Given this list of marker genes CEP76, CKAP5, VPS41, ZSCAN12, RTEL1, ENPP3, BNIP1, FAM185BP, MDH1 (malate dehydrogenase 1, NCBI Gene Id 4190), LTV1, FLAD1, GTF2IRD1P1, PSMD3, ANAPC2, MORC2, DNTTIP2, YIPF2, SLC44A1, RNA5SP473, CTR9, TTC31, SKIC3, SSNA1, MTFR2, TARDBP, EMC4, NFKBIL1, CRYZ, RPS3A, MED24, GDAP1, TIMM23, SFTA2, FAM98B, CCAR2, TVP23B, SNU13, OPLAH, ZNF581, KLK2, ZNF623, RPS28 (ribosomal protein S28), PRPSAP1, ZNF629, CHML, SENP7, RNF115, NDUFS7, PSTK, RER1, DHX33, ASB3 (NCBI Gene Id 51130), CBFB, CDC123 (cell division cycle 123), SMPD4 (sphingomyelin phosphodiesterase 4), TMEM245, COX6C, NAGPA, AOC1, CEP44, STRIP1, MRPL3, DNAAF11, U2SURP, BLOC1S5-TXNDC5, ERLIN2, BBS5, RNF185, GUCD1, CFAP68, LUC7L, NUP107-DT, YAE1-DT, SMARCAD1, FBXO8, USP37, RPUSD2, URB1, CXXC1, NOL8, RPS3, C6orf52, MCMBP, PINX1, CDKL3, LINC01547, FBXO45, ENDOV, NDC1, DNAAF10, GPATCH4, GPR89A, NKAPP1, NDUFV3, VPS13B-DT, NUP85, RTTN, OPN3, USP30, SSU72-AS1, PRR3, SYT12, TRIAP1, TMED1, TIGD4, NAF1, SLC35A1, FEN1, LAMTOR5, TBP, CSTF2T, COQ3, BRD7, TMEM41A, POLR1H, METTL6, SPHK2, ANGPTL4, TXN2, MIR4766, UBQLN1, FIZ1, WDR31, C2orf49-DT, VPS50, ST7 (NCBI Gene Id 93655), ADO, SNRNP27, CCNC, ZNF805, TSN, ARV1, BRWD3, EIF2S1, PITHD1, RTF2, LARS2, WIPF2, SRGAP3, NKAP, INTS1, TFIP11, IFRD2 (interferon related developmental regulator 2), ADSS2, VPS72, MACC1, NR2C1, RAB2B, GBA1LP, EIF2B5-DT (NCBI Gene Id 105374249), SERP1, WASHC2C, KRT18P33, SMG5, NUCKS1, NUDT5, HINT3, SUGP1, PLAA, MRPL54, NHP2, SLC7A6OS, KRR1, PSMG3-AS1, DDX18, TMED10, CENPS-CORT, ZBED5, SPNS1, CCT7, CHD8, USP40, MCF2L2, VARS2, ISY1, NUP205, ZNF133, SELENOOLP, SP2, SEPTIN7P14, ADNP, EEF1A1P23, LZTFL1, PCID2, C19orf81, KCNH2 (potassium voltage-gated channel subfamily H member 2), RBSN, EIF3H, EMC3, BUD13, YAE1, RAB18 (RAB18, member RAS oncogene family), WTAP, YBX1, COMMD3, ABCF2, MIR762HG, LINC03016, COMMD9, MTPAP, DOHH (NCBI Gene Id 83475), ZSCAN21, TIMM29, SCG3, EXOC4, ORMDL3, CHUK, LARP4 (NCBI Gene Id 113251), ZNF165, SLC38A6, ATP8A1-DT, INO80C, POLR1HASP, HSPB1P2, MORC1, ADSS1, NDUFAF5, PIH1D2, CCT4, PCSK6, SHARPIN, C8orf33, LINC01347, MRPL27, ZNF3, COMMD1, SMG8, TMEM230, ERI3, ADPRS, RFC3, TRIP4, EXOSC8, NUP133-DT, RPS7, GFI1B, PIGL, RPL29, CCNI, PEF1-AS1, FARS2, VPS51, ZDHHC6, MED23, GTPBP10, CWC25, PTPN11, MTBP (NCBI Gene Id 27085), ATP5PD, MRPS34, PSMD8, BAD, CNOT10, FAM21EP, GPS2, LRRC37A5P, IDH3B-DT, ZNF688, YJU2, CDKN2C, S100PBP, MIR5091, UFSP1, TSPYL6, DDX55, ISY1-RAB43, MAPKAPK5-AS1, ZFHX2, ZNHIT3, PPP4R1L, HEXA-AS1, PARG, CWC22, PRR14, ROMO1, SLC38A9, EIF3G, PRPF18, ZNF417, NME1, EIF5A, RTEL1-TNFRSF6B, SIN3B, SMPD4BP, CMSS1 (cms1 ribosomal small subunit homolog), PINX1-DT, MRPS31P5, SECISBP2, PPP2R3B, TOR1A, IFRD1, EXOC1, BBS1, SLC4A1AP, ENSG00000253986, ZBTB40, PSMA1, ZNF26, RNPC3, ALG10, RABGGTA, ZNF426, ADSL, POLR2J4, EEFSEC, CDKN2AIPNL (CDKN2A interacting protein N-terminal like), PPP4R3B-DT (PPP4R3B divergent transcript), SUB1, POLR3C, ACAD11, PPP4R3B, TMEM79, NRBF2, PCM1, HNRNPH2, MTLN, NKAPD1, NXT2, NDUFA12, SLX9, RRAGA, ARMC8, KLHL20, DNAJC1, TAF2, NBAS, AP4M1, FMC1, AFG2B, MEN1, REX1BD, RCAN1, NSUN6, DIABLO, DHODH, UQCC4, NFE2L1, GOLGB1, POLR2M (NCBI Gene Id 81488), AGA, LRRC59, LINC02842, SART1, ENSG00000263011 (NCBI Gene Id 124903629, novel transcript, sense overlapping ZNF205), GSTCD, ENSG00000232995, COPS8-DT, EMC2, SNORA50C, PPIP5K2, MKRN2, CERNA3 (competing endogenous lncRNA 3 for miR-645), GLB1L, NGDN, UBB, NDUFB7, COASY, SEC22B, MIX23, GPBP1, GTF2H4, INTS2, ZFPM2-AS1, MTF2, EIF2B1, SCP2, UBAP2L, SOCS1, MED28-DT, STOML2, RFC4, LIAS, CFAP52, CYB5RL, MKRN3, TMT1B, MCM8, TAF13, CDK12, TBC1D13, PANK4, ARFRP1, C1QL4, GLA, NELFA, PPP1R12B, AK6, HCG21, KLHDC4, RPLP0, SRP54-AS1 (NCBI Gene Id 102723366), ERBB2, NDUFV1, DDX1, MRPS23, RPF2, MCM7, ZDHHC7, STAM2, STMN3, SMG7-AS1, TEFM, GUSBP1, FAM228B, GARS1-DT, MRPL9, METTL2B, CRY1, RBBP4, CCDC86, IMPACT, TIGD6, ECSIT, RAB30-DT, PSMC3, PEX16, NORAD, TMEM14B, TUT1, PUM3, KLHDC9, KBTBD6-DT, CLUAP1, WDR37, KIF15, MRPL20, UBE2I, HERPUD2, MRPL53, BRMS1, ZNF408, FBXL12, VPS4B, TMEM205, CALM2, LSM10, ZSWIM8, MAPKAPK5, ARSK, MIS18A, IFT74, RPS25, MRPS31, RPTOR, ANKRD17-DT, DTL, PWP1, ENSG00000260830, ACO2, TMCO1-AS1, PEX26, RPA3, IKBKB-DT, BPNT1, SF3A3, CIAO3, MRPL40, MPLKIP (NCBI Gene Id 136647), UBC, ATF6-DT, TACO1 (NCBI Gene Id 51204), ZNF490, DPM3, EXOSC3, TMEM242, FAHD1, MIR4727 (microRNA 4727), HPS4, TBCCD1, TM9SF2, MRPL47, CHMP1B, EME1, DHX40, PEX14, TTC4 (tetratricopeptide repeat domain 4), CCZ1, ZNF221, CCDC146, BRPF1, GFM2, CDK7, TTC13, ZCCHC9, NME7, CDK5RAP1, LINC00680, NABP2, PCSK6-AS1, GINS3, PIGG, EIF3E, ITFG2-AS1, FASTKD2, BCL2L2, WDR53, FAM220A, LEMD2, GTF3C3, NSMCE2, PDE12, ENSG00000268129, MLEC, UFC1 (ubiquitin-fold modifier conjugating enzyme 1), TOX4, ZSCAN25, NUDT19P5, UBE4A, ZNF846, ANKRD40, ELP3, ANKRD17 (NCBI Gene Id 84177), PRADC1, NMRAL1 (NCBI Gene Id 57407), TAB3, EPCIP-AS1, SP8, RRP15, ZSCAN9, GM2A, HDAC4-AS1, METTL9, JRK, PPIG, GEMIN7, ZNF131, SEC11A, TRMT10C, TRPC4AP, FANCD2 (FA complementation group D2), LL22NC03-63E9.3, PFDN4, BRF2, BMS1, ATAD3A, NRAS, HELQ, BOD1L1, CHFR-DT, TXNL1, C1orf35, MYL12-AS1, FEM1A, AQR, PRKAB2, KAT5, CGGBP1, UMAD1, LDAH, ALS2, ZC3H18, IQCK, SLC35A5, SZT2, SCO1, PLEKHM3, BBX, FBXL18 (NCBI Gene Id 80028), CACYBP, TIMM10, NUP155, TENT2, WDR83OS (WD repeat domain 83 opposite strand), ESF1, RNF14P2, SUMF1, GMFB, HERPUD2-AS1, UBXN6, APTX, TRDMT1, TBCK (TBC1 domain containing kinase), ATP6V1H, USP31, GALNT16-AS1, GARS1, THAP8, DLAT, MMACHC, ADAT2, GTF2IP12, MRPL45P1, MINCR, PRPF31, AP4E1, MTO1, TJAP1, LYRM4, CCDC159, ADGRG7, ZNF524, PARL, SSU72, ENSG00000189229, FERRY3, EIF3F, MRPL1, SMG7, KBTBD6, DNAJC25-GNG10, SNHG17, PRIM2, FBXO7, PMF1-BGLAP, RPL18, POLR3A, CFAP57, ZNF205, OPA1, THUMPD1, CSTF2, FAM114A2, KCTD9, RIF1, DCP1A, UBP1, AKAP3, STK16, SRRD, WDR25, TOMM22-DT, VPS54, CYREN, NBPF25P, DNAJC16, FAF1, TUBGCP6, METTL15, RRM1, CSTPP1, COQ4, NAPG, TBL3, C12orf76, ACBD3, GTF2B, THAP1, SEPSECS, ZBTB8OS, RBM28, SEPSECS-AS1, SMC3, MDGA1, ZNF397, CCDC142, GTF2H3, RANBP10, B3GALT9, WDR4, GALC, C17orf75 (chromosome 17 open reading frame 75), VMAC, METTL17, TMEM208, ECHDC1, NCOA4, EDC3, ACOX3, PRAME, SESN1, NDUFB6, PATL1, CIAPIN1, POGZ (pogo transposable element derived with ZNF domain), SLC35A3, SLIRP, HARS2, POLR3B (RNA polymerase III subunit B), MAF1, SDAD1, AIMP1, AP2B1, ZNF514, ATR, ZNF223, FAM83A-AS2, PSMG3, ZKSCAN2, FIG4, PET117, PCYOX1L, CTNNB1, VCPKMT, HTRA2, URB1-AS1, MRPS15, SCAND1, WDR62, VWA8-AS1, IDH3B, NDUFA9, LAPTM4A-DT, TARS2, SNRNP35, DFFA, POLR2K, BANCR, SUPT7L, MDH1B, PGS1, PRMT7, MYO3B-AS1, ZNF396, GPATCH3, LMAN2, HYCC2, TBPL1, CLASRP, PRSS30P, DYNC2I2, PAXBP1, SLC24A1, MRPS33, CGB2, CASP9 (NCBI Gene Id 842), SNRPB, TRMT61B, TELO2, SLC39A9, ZNF461, RAD51B, ZNF785, GFM1, SPAST, MGRN1, GNG4, ST3GAL2, KIAA1143, RNMT, PSMB3, DPCD, UMPS, ISLR2, LAMP1, RALA, RAG1, MIR4519, APBA3, CENPW, TAF11, QRSL1, ANKFY1, LINC00824, PEMT, HNRNPA0, MARCHF8, SEC11C, NOC3L, TMEM167B, GIRGL, MTRF1, AP3S2 (NCBI Gene Id 8885), GUF1, NDUFB3, PARGP1, TMED9, LAPTM4A, POLR3F, RRP1B, CCN1, GPR107, TRUB2, SDHB, CALM3, SNHG25, LYST (NCBI Gene Id 1130), MAN2C1, POC1B-GALNT4, JPX, PSMB7, CHTF8, EMG1, ZNF501, BLOC1S1, MTERF1, DEDD2, UBE3B, DGCR8, HPS5, MPDU1-AS1, PTPN21, BNIP2, CWF19L1, BANP, DDX51, ZNF561-AS1, CCDC59, ZNF484, ALG1, UBE2Q1, ACAD9, ZNF791, ZNF830, CDK11B, YKT6, RPL9, SNRPF-DT, EXOC2, SCAP, ATXN2, ARHGAP1, FAM162A, MTIF2, NUTM1, NFX1, SETDB1, IQCC, LZIC, FAM135A, TSKU-AS1, CCDC124, PUS10, TMEM184C-DT, THEM4, REXO4, C2CD2L, CRBN, SNRPD3, HAGH (hydroxyacylglutathione hydrolase), FARSA, VPS26B, PHAX, ACP2, RAD17, MTERF4, SLC52A2, NDC80, EIF2D, LONP2, OAZ3, TMA16, RBM45, PFDN6, CFAP20, ALG3, SNRPC, NUP54, AHCY, CTSA, QTRT2, ZKSCAN3, DPAGT1, ZNF546, ANAPC15, TSEN15, SMARCAD1-DT, HDAC4, TMX2, ZNF391, MAPRE2, LTA4H, DHRSX, MRPL48, KDM8, MEF2A, DUS2, MCEE, ARHGEF1 (Rho guanine nucleotide exchange factor 1), TMEM248, BECN1, DNAJC7, PLD3, TNPO2, UQCC1, WDR83, ZNF197, RPSAP31 (NCBI Gene Id 391598), RPL26, NDUFB5, TFCP2, TRAPPC4, TRAF6, POC1B, ZNF268, PRKCSH, TULP2, RAD51AP1, ATF6, HOOK2, GEMIN6, ERH, C15orf40, MCTS1, ZNF426-DT, SIKE1, SLC36A1, CALCOCO1, NUP133, STAM, PPP5D1P, HEXA, SNAPC5, FLT3LG, LINC02882, SMIM12, MRPS35, ZNF394, TRMT5, TFAP2A, ARRDC1-AS1, HMGB1, CLK3, KIF9, COX7A2L (NCBI Gene Id 9167), TSNAXIP1, TMEM131, TOMM40L, WDSUB1, CHUK-DT, AAMP, TMEM9B-AS1, TRMT10A (NCBI Gene Id 93587), BMS1P4-AGAP5, ZNF317, CCNL2, PXN-AS1, FAM200A, USPL1, GUSBP11, TMEM128, MRPL30, ENSG00000293341, VPS26A, MRPS35-DT, POM121, RGS5, ABCA3, FCF1, SEC24C, HARS1, CCDC97, GORASP2, ZGPAT, FAM187A, QTRT1, TIMMDC1, TRMT44, NEK1, UVRAG, DNLZ (NCBI Gene Id 731607), ETAA1, UQCC6, RRAGC-DT, WDR24, GABARAP, ATAD2, FBXO15, SRRM5, LINC01128, RNA5SP21, GUSB, TTC1, COX19, GLUD1P3, IRGQ, ARL1, FDX2, MTMR4, MRPL55, GATC, FRMD1, GTF2IP20, SAXO1, FNBP1P1, CPNE2, EIF1AD, TOR1B, KCTD16, RNF216, SMIM30, C1orf43, MRPS31P4, ZMAT2, LRP6, WARS1, IFTAP (NCBI Gene Id 119710), NOC4L, KLHL18, AREL1, NOP10, BCL2L2-PABPN1, SNAP47, NOL7, HADHB, FAM117A, BUD13-DT, MANBAL, EIF4E2, ATAD3B, ZNF689, CCZ1P1, WASHC5, CYB561D1, ZDHHC16, SEC13, RRP36, CFAP410, ZNF502, NAT10, MTOR, PHF5A (NCBI Gene Id 84844), GIN1, WDR26, TOMM5, NCBP2, ARAP1, HIRA, TMEM101, ATL2 (NCBI Gene Id 64225), ZCCHC24, FAM50B, INTS12, ST7-OT4, TEX14, NSUN2, TBCD, HMOX2 (heme oxygenase 2), RPS20, FRA10AC1, MAP2K1, IPO4, RUVBL1, TFPT, PSMG2, MAIP1, PDE6D, CIDECP1, RLF, PDSS1, COMMD5, ZNF263, TMEM199, VAC14, CCT6B, YME1L1, DBR1, ATF7, FADS2, ABCB7, MRPS18C, SNHG33, EAF1, SNHG11, EBNA1BP2, PIGT, CDCA7, LSG1, BRIX1, TSR2, SENP1, ELF1, SRSF11 (NCBI Gene Id 9295), PALB2, PPT1, STX18-AS1, SAMM50, PNO1, ENSG00000272195, PSME3, POLR1F, LRRFIP2, ZNF16, MPHOSPH10, TOMM22, SKIC8, COX16, ERI1, TBCEL, RPIA (ribose 5-phosphate isomerase A), MIR5188, RPL4, TDG, EIF4E, WDR77, PRKCI, NECAP2, UBQLN1-AS1, CKMT2-AS1, NR1H3, CCDC163, IPO11, GNL1, CARD8-AS1, COMMD4, MZT2B, KCTD10, ATG4C, HDAC6, AURKA, POLR2C, MZT2A, INTS5 (integrator complex subunit 5), MIPEP, STEEP1, ALG10B, RNGTT, MYL12B, LINC00667, RNF187, TADA1, IFT56, KDM5C, ODAD3, JAGN1, SEC23IP, KATNB1, SAP30BP, NEK2, KBTBD4, SMIM13, THG1L, TMEM242-DT, NUDCD3, ZNF292, DBNL, AAR2, ZNF596, HEMK1, SNORD104, RANBP6, ZNF497-AS1, C2orf49, LAS1L, MRPL16, ATXN2L, STRADB, ZNF200, NEURL2, LAMTOR5-AS1, CDKAL1, MCRS1, ABCA11P, TSFM, SCYL3, SUDS3, KCTD5 (NCBI Gene Id 91152), CTDP1-DT, DNAJB12, RPL36, MFF-DT, COA1, ERLEC1, SMAP2, DNAJC30, TMEM258, EXD2, TMEM18, SLC27A5, ZNF614, PGAP3, HADHA, DYNC2H1, FAAP24, SNORD54, PRXL2B, TFIP11-DT, TYW3, AARS2, MRPL37, TSC1, GATB, ALKBH3 (NCBI Gene Id 221120), PSMB1 (proteasome 20S subunit beta 1), NDUFC2-KCTD14, BMS1P4, METTL25, PCLAF, CEP63, SNRPD1, NME1-NME2, CLPTM1, CNOT9, RIMOC1, SNRPE, LINC00115, ZNF576, LINC01098, TSKU, MCAT, ANAPC10, RRAGC, NMNAT1, WDR36, GTF2H1, SELENOH, TPI1P2, TIMM23B (translocase of inner mitochondrial membrane 23 homolog B), TIGD1, KCTD2, EFCAB7, ZNF212, GAN, ADAP2, FDXACB1, MRPL44, PCCB, MAP3K7, PHB2 (NCBI Gene Id 11331), CENPS (centromere protein S), LRRC40 (leucine rich repeat containing 40), HUS1, FBXL9P, ACCS, UTP4, MAGOH, KAT7, ZNF562, EFTUD2, CCDC174, AGGF1 (NCBI Gene Id 55109), HSF2BP, TMEM184C, LTO1, SF3B6 (splicing factor 3b subunit 6), LINC01287, FAM9B, NDUFS3, DEPTOR, MAU2, INTS14, TAF9, CARD8, ABHD17B, SNHG20, IREB2, MRPL22, C6orf89, NUFIP1, MRPL42, DRG2, POLR2J, EMC3-AS1, RABAC1, ALG5, EME2, SUPT16H, PPIL4, SLMAP, STX16-NPEPL1, RANBP2, CENPP, FBXO28, DNAJC18, RNU7-27P, MFF, WASHC2A, UBA5 (NCBI Gene Id 79876), PPP1R12C, SUGCT, ITGA7, VPS25 (vacuolar protein sorting 25 homolog), C12orf43, VWA8 (von Willebrand factor A domain containing 8, NCBI Gene Id 23078), ATP2B4, SLF1, BUD23, RTN4IP1, CLCN3, CLTC, SREK1, ERCC5, KAT14, POLDIP2, MTTP, FAM149B1, WSB1, AUP1, NOL12, STX8, THTPA, EOGT-DT, TMEM109, RPL37, ZNF561, CTBS (NCBI Gene Id 7811), MBD3L1, STX16, TRMT6, CHMP4A, WDR13, RPL23AP53, STARD10, RBBP5, GATM, RPS14, BORCS7-ASMT, KLHL12, CAMK2D, ZSCAN16-AS1, GLOD4, TM2D3 (NCBI Gene Id 80213), ATP6V1D, VPS13B, CCDC22, TRUB1, TTC32-DT, TOP3B, MICOS13, GRPEL2-AS1, CALCRL-AS1, DHX36, ZNRD2, ARL8B, GTPBP3, ATP13A4, CTDP1, PMPCB, SMIM20, INO80B, DPY19L4, AFG1L, ALKBH1, LCORL, NSA2, APOOL, VTI1A, CNBD2, HMGXB3, RECQL5, ZNF331, LINC00630, ZNF558, SEC14L1, MED15, RPS26, AP3M2, DNAJC25, ARHGEF7, MFAP3, ABCB8, CCDC103, INTS7, ECD, ATG13, TOR1AIP1, ENSG00000272008, RNF213-AS1, NUFIP2, FAM210A, UBL5, CSTF1, TAF3, MED18 (mediator complex subunit 18), CDCA2, NUF2, ABCF1, BOD1, GTF3C5, RAB30, PEF1, DPH1, ATF7IP2, SRD5A1, MITD1, SFSWAP, SEPTIN7P13, SPTLC1, MRPL13, CACTIN, LRP4-AS1, AP1G1, METTL4, STAT6, AOPEP, JMJD4, MED8, ZNF526, ZBTB17, FRS2, DDX60L, WDR70, ZBTB6, SRP54, TBC1D2, ARK2N, DHDDS, MALSU1 (NCBI Gene Id 115416), ST7-AS1, MIGA1, MRPL33, CFAP69, CNOT2, DYNC2LI1, PES1, FOXJ3, SNORD15A, ARPP19, CLPX, ABCA17P, C19orf38, ZNF2, GPR137, UBXN2B, AK9, ITGB3BP, CHCHD1, ZNRD2-DT, RAD1, CUL4A, RETSAT, MPZL3, EHMT1, LINC01666 (long intergenic non-protein coding RNA 1666), INO80B-WBP1, NDUFAF1, PRANCR, POLR2J3, TMEM167B-DT, KATNAL1 (katanin catalytic subunit A1 like 1), HSD11B1L, SLC35B1, RBL1, TMCO1, ZC3H6, EIF2A, KIAA0825, MRM3, MED27, UTP20, ZBED5-AS1, C1orf74, ZSCAN31, ATP6V1G2-DDX39B, ZKSCAN4, TPRKB (TP53RK binding protein), ATG3, FBXW9, MTX2, KNOP1, COIL, PSCA, LAMTOR3, RBM42 (NCBI Gene Id 79171), PFKM, BPGM, NDUFV1-DT, HEATR1, PNKD, C3orf85, PPP1R37, NDUFA7, TRAK2, SPPL3, ZC3HC1, MRPL20-AS1, COPS7B, ADAR, PEX13, MKLN1-AS, RAB3D, DDX31, SMTN, ZNF335, DNM1P35, BMS1P1, TNPO3, HARBI1, BORCS7, GRK4, TMEM237, WWP2, FAM21FP, FRG1, RAD54L, SNIP1 (Smad nuclear interacting protein 1), MIR3928, ABT1, POLL, EXOSC1, PDCD7, IPPK, KMT2D, ZNF580, MRPL39, EOGT, ESS2, TAF1C, CREBL2, PSMF1, TTC32, DCTN5, FBXL6, C1D, ZNF721, ZNF213-AS1, CNIH3, SAR1B, POLD3, NDUFC2, GGA1, TMEM203, DNAJB11, RIN3, C3orf38, PRMT3, RMDN3, ATP8A1, ZNF23, ALG14, CCZ1B, NOP14, PPCDC, NUP107, CHFR, ANXA2, NCBP2AS2, PPP6C, COX7B, ZNF507, XYLB, TMEM39A, GPALPP1, DZANK1, EIF2B5, FRG1GP, COX7A2, SMARCD2, CLN3, TIMM21, ZDHHC5 (NCBI Gene Id 25921), CALU, BANF1, GBA1, MTMR9, NRDE2, ATF7-NPFF, PRPF40B, CRYBG2, WDPCP, FBXW2, LINC00523, ATP5PB, TIPIN, C7orf50, NVL, RPUSD4, RNU6-271P, NDUFA11, ENSG00000221040, SPATA2, DMAP1, MNAT1 (MNAT1 component of CDK activating kinase), CNEP1R1 (NCBI Gene Id 255919), MFN2, TIMMDC1-DT, ATP5MC3, USE1, YIPF5, LUC7L2, FAM118B (family with sequence similarity 118 member B), RPF1, ASB6, ZNF644, RPL6, NAA20, RAD51C, STX18, RNPC3-DT, RPL32P3, MED28, ZWILCH, LINC01732, MAGOH-DT, RRN3, ADPGK, ZER1, COMMD2, GIHCG, SLC9A1, MARK4, THUMPD3, ZNF770, MBTPS2, LINC00690, BLZF1, COPS8, MARCHF7, FCSK, BLOC1S5, NCAPD3, RPS6KC1, FNDC3A, BRWD1, EXO1, SLC39A3, NCLN, TMEM109-DT, WDR46, NPHP1 (nephrocystin 1), MASTL, SLC35E1, ZCCHC7, GZF1, FRG1-DT (FRG1 divergent transcript), TYW5, ABCE1, NUP153, STAM-DT, MIR548AW, NDOR1, GOLGA8B, TNIP1, SNRPF, AMBRA1, ELMOD3 (NCBI Gene Id 84173), PMF1, SLC25A26, PEX3, NFS1, YARS1, CCDC191, SUCLG1, CEP89, BAZ1B, ECE2, MED19, TRMU, LTN1, POP4, MTPN, FRG1CP, PIN4, ATP6V1G2, ADPRM (NCBI Gene Id 56985), COQ5, MRPS22, GOLGA3, ZNF266, C19orf47, C9orf85, CWF19L2, TMEM9B, DHX33-DT, COQ9, TRAPPC9, EDC4, MECOM, ATP8B1-AS1, LINC01409, AGBL3, MIR4512, CPEB4, ARFIP1, CEP57L1, GLUD1P2, PSMD6, here is a description of the gene set: studied in species Homo sapiens from publication Yevshin I, Sharipov R, Kolmykov S, Kondrakhin Y, Kolpakov F (PMID 30445619) Genes containing one or more binding sites for (DIDO1) in their promoter regions (TSS -1000,+100 bp) as identified by GTRD version 20.06 ChIP-seq harmonization. Human Gene Set: DIDO1_TARGET_GENES